The following is a description of a gene set: Human Gene Set: THAKAR_PBMC_INACTIVATED_INFLUENZA_AGE_21_30YO_NONRESPONDER_7DY_DN from publication Thakar J, Mohanty S, West AP, Joshi SR, Ueda I, Wilson J, Meng H, Blevins TP, Tsang S, Trentalange M, Siconolfi B, Park K, Gill TM, Belshe RB, Kaech SM, Shadel GS, Kleinstein SH, Shaw AC (PMID 25596819) species: Homo sapiens Genes down-regulated in peripheral blood mononuclear cell 7d vs 0d in young adults (21-30) (nonresponder) after exposure to Inactivated influenza vaccine, time point 7D To elucidate gene expression pathways underlying age-associated impairment in influenza vaccine response, we screened young (age 21-30) and older (age >= 65) adults receiving influenza vaccine in two consecutive seasons and identified those with strong or absent response to vaccine, including a subset of older adults meeting criteria for frailty. PBMCs obtained prior to vaccination (Day 0) and at day 2 or 4, day 7 and day 28 post-vaccine were subjected to gene expression microarray analysis. We defined a response signature and also detected induction of a type I interferon response at day 2 and a plasma cell signature at day 7 post-vaccine in young responders. The response signature was dysregulated in older adults, with the plasma cell signature induced at day 2, and was never induced in frail subjects (who were all non-responders). We also identified a mitochondrial signature in young vaccine responders containing genes mediating mitochondrial biogenesis and oxidative phosphorylation that was consistent in two different vaccine seasons and verified by analyses of mitochondrial content and protein expression. These results represent the first genome-wide transcriptional profiling analysis of age-associated dynamics following influenza vaccination, and implicate changes in mitochondrial biogenesis and function as a critical factor in human vaccine responsiveness., and this is the list of marker genes: ELF4, CIDEB, FLII, CSTB, ARPC3, ZFHX3, TUBA1C, BRPF1, NLRC5, TBC1D9B, EIF4H, ACO2, RAP1GAP2, MIAT, PRKCSH, ACVR1B, CUX1, PPP1CA, RAI1, HERPUD1, SDF4, RHOT2, ATXN1L, YPEL2, SLCO3A1, MAF, EP300, ZYX, IL32, KMT2A, FYN, RMDN3, SEC22C, ITFG2, DCAF7, CD99, SLFN13, SMPDL3A, KLF13, TNFSF12, PTGER2, TM9SF4, MIDEAS, DUSP18, ZFPM1, STAT6, ECH1, ALDOA, ITGAL, SMARCC2, B4GALT5, BHLHE40, ITGB2, OSBPL7, CLOCK, RANBP3, SDE2, PITPNM1, CSAD, CLSTN1, LAG3, ATG4B, NPIPA1, ATP2A2, MBD2, PSMC4, ENTPD4, SRPK2, DNASE1L1, SIGMAR1, ADGRL1, CAMK2N1